Given this list of marker genes Cma1, Enpep, Ace, Gzmn, Ace2, Ctsg, Ces1d, Ctsd, Cpa3, Atp6ap2, here is a description of the gene set: Reactome Pathway: Metabolism of Angiotensinogen to Angiotensins This event has been computationally inferred from an event that has been demonstrated in another species.<p>The inference is based on the homology mapping from PANTHER. Briefly, reactions for which all involved PhysicalEntities (in input, output and catalyst) have a mapped orthologue/paralogue (for complexes at least 75% of components must have a mapping) are inferred to the other species. species: Mus musculus part of: Peptide hormone metabolism electronically inferred by orthology from the curated human pathway